The following is a description of a gene set: Mouse Gene Set: GOMF_COBALT_ION_BINDING species: Mus musculus Binding to a cobalt ion (Co2+)., and this is the list of marker genes: Myt1l, Slc11a2, Rnpep, Pml, Nudt16, Epas1, P2rx2, Cpe